The following is a description of a gene set: Genes up-regulated in the intestine after the tissue specific knockout of PTEN by Cre-lox. Intestinal polyposis, a precancerous neoplasia, results primarily from an abnormal increase in the number of crypts, which contain intestinal stem cells (ISCs). In mice, widespread deletion of the tumor suppressor Phosphatase and tensin homolog (PTEN) generates hamartomatous intestinal polyps with epithelial and stromal involvement. Using this model, we have established the relationship between stem cells and polyp and tumor formation. PTEN helps govern the proliferation rate and number of ISCs and loss of PTEN results in an excess of ISCs. In PTEN-deficient mice, excess ISCs initiate de novo crypt formation and crypt fission, recapitulating crypt production in fetal and neonatal intestine. The PTEN-Akt pathway probably governs stem cell activation by helping control nuclear localization of the Wnt pathway effector beta-catenin. Akt phosphorylates beta-catenin at Ser552, resulting in a nuclear-localized form in ISCs. Our observations show that intestinal polyposis is initiated by PTEN-deficient ISCs that undergo excessive proliferation driven by Akt activation and nuclear localization of beta-catenin. studied in species Mus musculus from publication He XC, Yin T, Grindley JC, Tian Q, Sato T, Tao WA, Dirisina R, Porter-Westpfahl KS, Hembree M, Johnson T, Wiedemann LM, Barrett TA, Hood L, Wu H, Li L (PMID 17237784) Mouse Gene Set: HE_PTEN_TARGETS_UP, and this is the list of marker genes: Bmyc, Plagl1, Pdgfa, Zfp369, Cdk6, Trp53, Mycn, Rb1, Ccnd3, Maf, Ect2, Ccni, Akt2, Itgb1, Fgf1, Cdkn1a, Tgfb2, Elk3